The following is a description of a gene set: Genes predicted to be targets of miRBase v22 microRNA hsa-miR-5680 in miRDB v6.0 with MirTarget v4 prediction scores > 80 (high confidence targets). from publication Chen Y, Wang X (PMID 31504780) species: Homo sapiens Human Gene Set: MIR5680, and this is the list of marker genes: ATM, DGKI, GAPT, C12orf75, IAPP, SMAD7, NPM1, ARB2A, CBX5, OPHN1, DPH6, FAT1, TAB2, KDR, CBLB, CYP26A1, FGF12, KLHDC1, GMFB, EPHA5, GOLPH3L, CERT1, RFXAP, CYP39A1, CNEP1R1, TRDN, CD93, FRS2, MAP3K2, MMAA, WDR76 (WD repeat domain 76), CUL4A, AKT3, DESI1, CHAMP1, CEP70 (NCBI Gene Id 80321), SH3BP5, SENP6, PTPRN2, CADM2 (cell adhesion molecule 2), APPBP2 (NCBI Gene Id 10513), MTCH2, RRM1, PHEX, P4HB, LIFR, RHOJ, GABRB2, AKAP5, EPHA6, PANK1, TPR, PHIP, FGB, ATP8B2, TRIB2, GDNF, NFIB, CYP4X1, OSBP2, LRRTM2, MSL2, DENND1B, PLXNC1, SLF1 (SMC5-SMC6 complex localization factor 1), ZMPSTE24, LRP3, LPP, RTKN2, PTBP3, PLCB2, MTCL3, TBL1XR1, ELMOD2, SPOCK3, IL22RA2, KCNJ3, MAP2K4, ZNF423, TTF2 (transcription termination factor 2), GUCY1A2, SLC23A2, OSBPL3, TRIM33, KCNG3, GALNT7, SANBR, SCD, RABIF, CCDC89, DOCK9, RAP2B, LARP4, RBM47, FGFBP3, GXYLT1, PDGFRL, CTTNBP2, DCUN1D4, TNFAIP8, ACSL4, EGFL6, PIGY, GNB4, CHL1, PTGER3, KLHL36, TESK2, PHLPP2, MED12L, MDM1, STRN, PITPNM2, SLC11A2, NRCAM, SLC25A53, AGO3, GADD45B, ATXN1, NLGN4Y, HECW2, RAB2A, ZMIZ1, HSPH1, GMCL1, SPAG9 (NCBI Gene Id 9043), PEDS1, G3BP2, TMEM196, PCSK6, FGF2, ANKS1B, KCND2, GABPA, MEGF9, PYURF, NSL1, UNC50, GPR63, GALNT1, TEAD1, SPIRE1, FNIP1, RALBP1, PAPOLA, OCRL, ADIPOR2, POU2F1, DDOST, KIAA1549, MAX, EXD2, RBMS3, TMEM214, EDEM3, MYT1L, MED1, STK3, CBFB, SLC35D2, RBM3, DST, SLC25A15, JPH4 (NCBI Gene Id 84502), RAP1A, RAP1GDS1, CYTH3, ZCCHC2, RHOQ, ATP8A1, SPEF2 (sperm flagellar 2), SEL1L, AFF1, SOCS4, SUSD6, ANAPC7, ENAM, PPP6R3, HMGA2, CHIC1, NCOA2, TTC33, RHOBTB3, TAOK1, GRM4, BEST4, NADK, MYO16, REV3L, NADK2, TLK1, TMEM167A, WDFY3, MRE11, PHC3, NAA15, LRAT, NPR3, SPCS1, DNMBP, SPATA2 (NCBI Gene Id 9825), COL25A1, UBE2H (ubiquitin conjugating enzyme E2 H), CREB1 (NCBI Gene Id 1385), PAX9, GLRA2, KLHL8, PARP11, DMD, TMEM132B, ITGB3BP, IL1RAP, HACD3, CHMP2B, TCHP, CNTNAP3, OLFM3, PRKG1, HYCC2, PIP4P2, DENND4A, SSPN, AFDN, RAB9B, ZNF441, GORASP2, DDX46, AFF4 (NCBI Gene Id 27125), PALS2, SERAC1, ZNF829, TTC9, CCDC102B, ZMAT4, PPP1R15B, GCC2, BCAT1, RPS6KB1, DISC1, WIPF1, NQO1, DCAF6, CYCS, IKZF2, RAPH1, PTPRJ, CDK6, COL5A2, EPB41L5, TMOD3, KLHL12 (NCBI Gene Id 59349), TET2, RIMS2, ALG10B, PDHX, DCUN1D5, ONECUT2, EOMES (NCBI Gene Id 8320), TMEM255A, CDH19, KCNJ15, GRHL3, EIF5A2, ZC3H8, GPATCH2L, EPB41L4A, NT5E, KLF12, ZNF460, NXPH2, NSUN7, DPP4, DNAJB4, GRAMD1C, TBC1D8, SFXN1, OSBPL8, SS18L1, CTCFL, EIF4E3, TCF12, SMARCA2, EIF4E, SLC16A12, CGGBP1, TMTC3, ZNF644, PTPRN, MON2, CAMSAP2, SKIL, SLC22A4, KANSL1L, CDC40, DOCK3, EDIL3, FUCA1, PHLDA1, GRIK1, EPM2AIP1, C18orf32, SEPTIN7, ADAM10, AKAP7, KMT2C, OAF, YPEL2, LRRC34, KPNA1, ZNF284, ZKSCAN1, HOXA7, GRAMD2B, BMPER, MMP24, TMEM97, BEND4, CALCRL, DPYD, ZDHHC20, SESTD1, TCERG1L, SUZ12, SLITRK6, STRBP, OMG, LRRC4, APBB2, CCNA2, NETO1, TMEM123, P4HA2, CACNB4, NEXMIF, MBNL3, FCHO2, BTG1, PRKACB, PRRX1, BCL10, DRAM2, KDM5D, SLC40A1, ABTB3, CLOCK, AP3M2, AZIN1, ARHGAP12, CENPC, FBXO48, SYNPO2, NPAS3, STIM2, PECAM1, UBE2V2, FHIP2A, HOOK3, PALMD, NR1D2, HOMER3, PCNX1, ISCU, PHF2, GDAP1L1, LNX2, CPEB2, SLC46A3, SLC26A7 (NCBI Gene Id 65015), SEPTIN2, APC, GORAB, LRRC42, ZSWIM5, TAFA1, GPM6A, NLGN4X, STON2, PGR, CREBBP, RBM12, AMACR, SLC6A15, PLEKHA5, PIEZO2, WDR26, SMC5 (NCBI Gene Id 23137), LMNB2, CPB1, TRIM5, TMEM135, CLCN3, CHD6, NWD2, SAP30L, THEMIS, SNCA, TRPS1, IMPG2, TENM1, PLXNA4, CAMK2G, FBXO25, EP300, TOR1AIP2, PRLR, BTBD1, PHF6, RAB23, SLC19A2, ABRAXAS1, BANP, VAV3, ANKRD27, CLCN5, STK17B, WWC2, LARS1, FANCE, SBDS, SECISBP2L, SMIM7, CYP2F1, MOSPD1, TYW5 (tRNA-yW synthesizing protein 5), CAMK1D, TXNDC16, SNX18, ANTXR2, NSD2, VLDLR, GNAO1, MAPRE2, FRMD3, SLC25A18, RBM27, TAGAP, ARHGAP42, DYNC1I1, MTUS2, MITD1, HECW1, DUSP1, PPM1E, VGLL3 (NCBI Gene Id 51159), CPSF6, FEM1C, FOXK2, B3GALNT2, NCKAP1, SENP7, PAX3, RNF111, IL33, KATNBL1, ZNF704, UHMK1, SLCO6A1, DIMT1, SS18, AVPR1A, SLC25A40, ZNF431, BPNT2, MBOAT2, ESR1 (NCBI Gene Id 2099), SNCAIP, SYNJ2BP, ATRX, DHX15